Given this list of marker genes Chrnb2, Drd1 (NCBI Gene Id 77537), Fos, Grin1, Grm7, Tbr1, here is a description of the gene set: Mouse Gene Set: GOBP_CONDITIONED_TASTE_AVERSION studied in species Mus musculus A conditioned aversion to a specific chemical compound as a result of that compound being coupled with a noxious stimulus.